Given this list of marker genes RAI1, RERG, SPC25, FBXO33, ATF7IP, PPP2R1B, EVC2, PHKB, SAMD4A, OTP, RAB11FIP2 (RAB11 family interacting protein 2), RRAGD, SCLT1, LHX6, USP53, IGF1R, AKAP5, BCAP29, TAPT1, TSHZ2, RETREG1, TENT4B, OXR1, SLC10A7, KRCC1, GABPA, TMED5, DACH2 (dachshund family transcription factor 2), IL10, PTER, PAX3, TMEM33, NOX4, LRRC2, RPAP3, LIN9, COX20, HOOK3, DCP2, SDR16C5, SLC35F3, CC2D2A, DLD, ASPH, DUSP1, FNIP1, HYDIN, PLAGL1, JMJD1C, ZFHX4, DCUN1D5, MIDEAS, ZNF280C, DUSP10, MTFR1, AZIN1, ADAM18, DLG1, CHIC1, MPZL2, MMP7 (matrix metallopeptidase 7), PTPRD, NLRP2, RPL36A, PFDN4, BPTF, KDM2B, PLSCR3, TARDBP, TSC22D2, TCAIM (T cell activation inhibitor, mitochondrial), NEPRO, LRRC19, SMURF1, TRIM36, AGO4, SLC30A1, VEZT, AIRIM, BICD2, SNX16, STRIP2, PAPOLG, FAXC, FCRL1 (NCBI Gene Id 115350), CEP170, HSPA4L, P2RY1, RHPN2, SPO11, SIM1, KCNJ2, DSC2, ITGBL1 (integrin subunit beta like 1), SCEL, JPH4, RNF4, TCF7L2, NDUFA5, SEPHS1, GAB1, MR1, RBM26, INTS6, HEATR5A, IL21, NETO2 (neuropilin and tolloid like 2), RAB21, ZNF518A, TSHZ1 (teashirt zinc finger homeobox 1), SPRING1 (SREBF pathway regulator in golgi 1), SEC24B, NFAT5, YAP1, MTX2, MKS1, UBE3A, FAM174A, KCMF1, AHR, PHIP, PRR7, TNPO1, PPP4R2, ATXN1, ENTPD7, SLC12A6 (NCBI Gene Id 9990), EMCN, NWD2, SGPP1, EMB, KLHL1 (kelch like family member 1), KIAA1958, SLC4A10, DGKE, PLCH1, GLRX3 (NCBI Gene Id 414229), CAMTA1, SPOCK3, OTUD6B, GSDME, CNOT6, PPDPFL, NOL4, RABGAP1L, SCRN3, LYSMD3, NIPSNAP3B (nipsnap homolog 3B), CDV3, LYN, SNX4 (sorting nexin 4), PRKAR2A, NLGN1, ETNK1, PHAX, PPIL3, ATP6V1H, ELF2, SCARA5, NLK, SUOX (sulfite oxidase), TRIM25, BNC2, TMPRSS11D, ID4, UGDH, TNRC6B, FZD3, LPAR1, COG6, SP3, IMMP2L, MGAT4A (alpha-1,3-mannosyl-glycoprotein 4-beta-N-acetylglucosaminyltransferase A), RASSF6, CLVS2, RGPD1, MAPK1, MICAL2, PAXBP1, CCDC144NL (NCBI Gene Id 339184), RAB12, PTPN9, DUSP8, GSAP, CCDC89, here is a description of the gene set: from publication Chen Y, Wang X (PMID 31504780) Human Gene Set: MIR379_3P_MIR411_3P studied in species Homo sapiens Genes predicted to be targets of miRBase v22 microRNA hsa-miR-379-3p, hsa-miR-411-3p in miRDB v6.0 with MirTarget v4 prediction scores > 80 (high confidence targets).